Given this list of marker genes TIAM1, PRKACA (NCBI Gene Id 5566), EPHB2, CFL2, PTEN, TRIO, DVL1, AKT1, PARD6A, MAPKAPK2, TPPP, ABL1, MAPT, DIAPH1 (diaphanous related formin 1), GSK3B, STAT3, MARK2, LIMK1, CLASP1, CDK1, MARK1, PAK1 (p21 (RAC1) activated kinase 1), TESK2, KIF2C, ROCK1 (Rho associated coiled-coil containing protein kinase 1), MAP1B, WNT3A, SPRED1, STMN1, PTPRA, AURKB, RAC1, GNAQ, CAMK4, NTRK2 (NCBI Gene Id 4915), NTRK1, NTRK3, PHLDB2, DPYSL2, TAOK1, SRC (SRC proto-oncogene, non-receptor tyrosine kinase), PRKCA, CDC42, APC, MAPRE1, RHO (rhodopsin), CLIP1, F2RL2, here is a description of the gene set: studied in species Homo sapiens Human Gene Set: WP_MICROTUBULE_CYTOSKELETON_REGULATION Microtubule cytoskeleton regulation